The following is a description of a gene set: from publication Yevshin I, Sharipov R, Kolmykov S, Kondrakhin Y, Kolpakov F (PMID 30445619) Human Gene Set: SS18_SSX1_FUSION_UNIPROT_Q8IZH1_UNREVIEWED_TARGET_GENES Genes containing one or more binding sites for (SS18_SSX1 FUSION_UNIPROT_Q8IZH1_UNREVIEWED) in their promoter regions (TSS -1000,+100 bp) as identified by GTRD version 20.06 ChIP-seq harmonization. species: Homo sapiens, and this is the list of marker genes: LFNG, RUNX1T1, CLN6, B3GNT7, RUNDC3A, PTPN9, MPP7, CPTP, THAP1, ETV1, AKAP6, ZNF131, TMEM260, CTIF, PRKAG2, WNT4, CD63, ARHGAP32, LINC00705, PAG1, ANO7, ARID5B, ANGPT1, TRPS1, PKD1P5, CCNE1, ATP5MC1P1, DNAAF6, MXI1, RAB2A, RNA5S13, LINC01230, NKAIN2, RALB, FHL1P1, RFX7, HES3, LINC01275, NUDT16-DT, MAP2, EZH1, CDHR17P, SATB1, ASAP2, ESRRA, PCDH1, FMNL1-AS1, LINC03025, ST7, VPS13B, MDM2, CALCRL-AS1, NKAIN4, GLUL, TCF7L1, FGFR1, HLF, SRRM3, NFXL1, LINC01101, CRYAA, SYMPK, ARHGDIA, RNU6-948P, TXNL4A, RIIAD1, LINC01385, DUSP23, NPIPB4, RNU6-535P, MRPS10P1, TBC1D5, SEMA3E, RRBP1, BORA, LINC01994, NOL4L, RAB3IL1, ELFN1-AS1, NFIB, IRX3, DAB2 (DAB adaptor protein 2), NCKAP5-AS2, NPAT, LAMA3 (NCBI Gene Id 3909), EBLN3P, USP53, ADORA1, RASA4, USP35, PLCE1-AS2, NRXN2, ADRA2A, BNIP2 (NCBI Gene Id 663), SNORD74B, EML5, EXOSC8, HES2, TCP11L2, PFKFB3, ENSG00000274432, BLACAT1, ALX4, CROCC, CEBPA-DT, ST7-AS1 (NCBI Gene Id 93653), GBX2, HHAT, LRMDA, LINC02454, AGBL5-AS1, IQCH-AS1, MBD6, LINC01523, FLRT3, TMEM30B, AK7, INTS11, CFAP46, PAN3, CADM1-AS1, CCDC178, EYA1, RTN2, AGPAT3, ARFGAP3, ENAH, COL26A1 (collagen type XXVI alpha 1 chain), CCSAP, DM1-AS (NCBI Gene Id 109729182), CCDC117 (NCBI Gene Id 150275), POLRMT, NRBP2, AMZ1, ASPHD1, TLE4, FOXL1, AIG1, LRRC4, CNPY1, TMEM181, FMNL1-DT, CERS4, ZNF385D, HTR3B, HOXA-AS3, SULF1, OGFR, LINC02698, ARHGAP26, ATM, LIMS1, SOCS3, LARS1, ROBO2, FAM41C, TSPO, HSPE1, HSPA12A, DPP7, DTWD1, EEF1A2, CREM, BATF3, OTX1, F7, MLLT3, TRIM2, PTCH1, TCEA2, PCDH7, RUNDC3A-AS1, FAM227B, LINC01569, SALL4, ZNF664, OLA1, ARRDC2, WEE1, GPR155-DT, TRMT10A, MTX1, RAN (NCBI Gene Id 87046), NTNG2, LINC00229, RPH3AL, TMEFF2, TBC1D16 (TBC1 domain family member 16), ARHGDIG, FMNL1, HOXA4, TPM1, KCNQ2, LMO7-AS1, IGF2, TMTC2, ALG5 (ALG5 dolichyl-phosphate beta-glucosyltransferase), LINC02239, RHPN1, SHB, LINC00900, ARHGAP15, DST-AS1, SEC62, DACH1, CFAP410, ECEL1P2, ZNF385D-AS2, RHOQ, SH3PXD2A (SH3 and PX domains 2A), KCTD21, TSPAN33, ZNF516-AS1, OGFOD3, AKAP8L, PRDM15, E2F7, DUSP4, SOX18, RIC8A, MYC, EPB41L1, MEG9, CLYBL, RASGRP3, FGF19, ANKRD20A3P, ITGA2B, AGPAT2, PWWP3A, MTCO3P12, PLIN5, ZBED4, CLSTN1, WDR74, H3-3B, PLXNB1, HSPD1, DNM3, SOX2-OT, USP17L24, JAM2, CECR2, C1orf174, LINC01972, FOXO3, TEDC2-AS1, ADARB1, LINC02806, UBL4A, RNU2-2P, STAU2-AS1, ARHGEF1, MN1, ING1, PRSS56, CKB, ENSG00000228133, PHACTR3, LINC03000, TNXB, PSEN2, RNF39, GIT1, ENSG00000272195, SLC1A3, CEP170B, NEUROG3 (neurogenin 3), TMEM218, GPNMB, HHIP, CKS1B (CDC28 protein kinase regulatory subunit 1B), CACNA2D1, HSPE1-MOB4, RN7SKP276, THSD7A, EHBP1-AS1, ZBTB46, SEMA3C, ST7-OT4, CD63-AS1 (CD63 antisense RNA 1), CBX4, CIMIP2C, MIR615, ESPNP, MPP3, CREB5, ZNF395, PCGF3, METTL15, EFNA5, METRN, C9, RCN1, CSPG4P13, SELENON, SSR4P1, ROCK1, GCH1, ACADL, COL9A3, EPHA4, RPL7P30, GGH, THBS3, AGBL5, C1QTNF12, OSBP, RNU1-117P, PCOLCE, ENDOV, CCDC92, LSP1, NEDD4, DNAI3, ZCCHC7, NUDT4, ZNF516, PKHD1L1, PCOLCE-AS1, SLITRK3, OTUB1, DHX40, SSH2, FOXA3, GATA6-AS1, THSD4, ASXL1, CTSC, MDM1, ZNF469, GRM7, DYNC1I2, RAB3C, CRTC2, TMOD1, SERINC2, SERHL2, TSPAN12, TIMM44, NOTUM, ST6GALNAC6, CNNM2, ATP1B1, SMG1P4, SEMA4C, TCF4, PPL, RBP4, GATA6, SULT2B1, HOXC12, MARCHF10, TMEM45B, WNT10A, SLC12A9, NUDT16, SKAP1, RFX3, KMT2D, TBL1XR1, FAM99B, PTHLH, RGL2 (ral guanine nucleotide dissociation stimulator like 2), PRDM16-DT, MIR3169 (NCBI Gene Id 100422973), COBLL1, PPM1N, AFP, DST, COL20A1, KITLG, TUT4, CD274 (NCBI Gene Id 29126), RNA5S9, TCF7L2, SRCIN1, LIN28B-AS1, LINC01235, TMEM91, STAT5B, CNR1, SLC24A4, SEZ6L2, AFF3, RFX3-DT, CD8A, FOXP2, LGR5, LY6E-DT, PGAP6, LMO7, SNX12, SMARCD3, MTTP, KCNMB4, FOXD3-AS1, KLF11, HNRNPA3, PCBP3, ULBP2, TASOR, LTBP3, ENSG00000203900, SAMD11, COL8A2, OLFM2, UNC13D, PTGER2, EMX1, GOLGB1, DGLUCY, DENND1A, ELOVL6, RAB37, TEX9, AP3B1, RPL39P40